Given this list of marker genes CNGB3, CNGA4, CNGA3, CNGA1, CNGB1, CNGA2, here is a description of the gene set: A protein complex that forms a transmembrane channel through which cations ions may pass in response to an intracellular cyclic nucleotide binding to the channel complex or one of its constituent parts. Human Gene Set: GOCC_INTRACELLULAR_CYCLIC_NUCLEOTIDE_ACTIVATED_CATION_CHANNEL_COMPLEX studied in species Homo sapiens